Given this list of marker genes SKA1, KNL1, NUF2, SKA2, MIS12, CCNB1, ZWINT, BUB1, DSN1, CENPF, NSL1, BUB1B, PMF1, SPDL1, SPC25, SPC24, PLK1 (NCBI Gene Id 5347), SKA3, NDC80, BOD1, here is a description of the gene set: The region of a kinetochore most external to centromeric DNA; this outer region mediates kinetochore-microtubule interactions. Human Gene Set: GOCC_OUTER_KINETOCHORE studied in species Homo sapiens